Given this list of marker genes PLA2G10, GPAT3, GPAT2, AGPAT1, GPD2, PLA2G5, GPAT4, GNPAT, AGPAT5, GPD1, DDHD1, PLA2G2F, PLD6, GPAM, PLA2G2A, MIGA2, LCLAT1 (NCBI Gene Id 253558), LIPI, PLA2G1B, AGPAT3 (NCBI Gene Id 83745), ACP6, PLD1 (phospholipase D1), LPCAT4, AGPAT4, PLA2G4D, PLA2G4A, LIPH, PLA2G2E, PLA2R1, GPD1L, PLD2, ALPI, LPCAT1, AGPAT2, MIGA1, PLA2G12A, PLA2G4B, DDHD2, PLA2G2D, here is a description of the gene set: Reactome Pathway: Synthesis of PA studied in species Homo sapiens In the de novo synthesis of phosphatidic acid (PA), lysophosphatidic acid (LPA) is initially formed by the esterification of sn-1 by glycerol 3-phosphate acyltransferase (GPAT) from glycerol 3-phosphate (G3P). Next, LPA is converted to PA by a LPA acyltransferase (AGPAT, also known as LPAAT). In addition to this, PA is also formed when phosphatidylcholine (PC) is hydrolyzed by phospholipases D1 and D2 (PLD1 and 2). PA is involved in acyl chain remodeling via cleavage by phospholipases followed by reacylation by acyltransferases. part of: Glycerophospholipid biosynthesis